Given this list of marker genes UBXN11, WDR6, PTPN13, RASAL2, KIDINS220, RND1, MUC13, ALDH3A2, STMN2, PLXNA1, PKP4, DST, RRAS2, FAM135A, PLEKHG5, LEMD3, CPD, DSP, DLG5, KIF14, ARHGAP35, CCDC88A, PIK3R2, ANKRD26, STIP1, VANGL1, TXNL1, CAV1 (caveolin 1), FLOT2, FAM83B (family with sequence similarity 83 member B), EPHA2, VANGL2, TMEM59, RBMX, ARHGAP5, DEPDC1B (DEP domain containing 1B), PIK3R1, EPSTI1, GRB7, TFRC, FRS3, FRS2, here is a description of the gene set: species: Homo sapiens Reactome Pathway: RND1 GTPase cycle RND1 is an atypical RHO GTPase from the RND subfamily. RND1 is constitutively bound to GTP and lacks GTPase activity. No guanine nucleotide exchange factors (GEFs), GTPase activator proteins (GAPs) or guanine nucleotide dissociation inhibitors (GDIs) act on RND1. RND1 localizes to the plasma membrane, but can be extracted from the plasma membrane and sequestered to the cytosol upon phosphorylation-induced binding to 14-3-3 protein. RND1 antagonizes RHOA, leading to reduced actomyosin contractility and loss of stress fibers and focal adhesions, which results in a rounded cell phenotype. RND1 plays a role in embryogenesis, neuronal development, myometrium changes during pregnancy, and angiogenesis. RND1 is frequently downregulated in cancer and is implicated as a tumor suppressor, but may play an oncogenic role in some cancer types. RND1 expression increases in response to anti-cancer agents and in may be involved in resistance to treatment. For review, please refer to Mouly et al. 2019. part of: RHO GTPase cycle